Given this list of marker genes CACNB2, TRDN, CACNB4, CACNG7 (NCBI Gene Id 59284), CACNG6, CACNA2D4, CACNG3, CACNB3, RYR2, CACNB1, ASPH, CACNG1, CACNG2, CACNA2D3, CACNA2D1 (calcium voltage-gated channel auxiliary subunit alpha2delta 1), CACNG4, CASQ1, CASQ2, CACNG5, CACNA1C, CACNA2D2, here is a description of the gene set: Cardiac-type VGCC-RYR signaling. Pathway ID: N01639. Pathway type: Reference. Pathway class: nt06528 Calcium signaling. Human Gene Set: KEGG_MEDICUS_REFERENCE_CARDIAC_TYPE_VGCC_RYR_SIGNALING Pathway Definition from KEGG: Ca2+(extracellular) -- CAV1.2 -> Ca2+(cyto) -> (RYR2+TRDN+JCN+CASQ) -> Ca2+(cyto) studied in species Homo sapiens